Given this list of marker genes Umod, Lrp11, Ntrk1, Avpr1a, Atp2b4, Pkd2, Pkd2l1, Nfat5 (nuclear factor of activated T cells 5), Aqp2, Pik3ca, Krt8, Lrrc25, Sipa1, Plec, here is a description of the gene set: Mouse Gene Set: GOBP_RESPONSE_TO_WATER Any process that results in a change in state or activity of a cell or an organism (in terms of movement, secretion, enzyme production, gene expression, etc.) as a result of a stimulus reflecting the presence, absence, or concentration of water. studied in species Mus musculus